The following is a description of a gene set: Human Gene Set: GOCC_CILIARY_BASAL_BODY A membrane-tethered, short cylindrical array of microtubules and associated proteins found at the base of a eukaryotic cilium (also called flagellum) that is similar in structure to a centriole and derives from it. The cilium basal body is the site of assembly and remodeling of the cilium and serves as a nucleation site for axoneme growth. As well as anchoring the cilium, it is thought to provide a selective gateway regulating the entry of ciliary proteins and vesicles by intraflagellar transport. studied in species Homo sapiens, and this is the list of marker genes: CBY1, CROCC (ciliary rootlet coiled-coil, rootletin), MARK4, TOGARAM1, PDZD7, SSX2IP, TAPT1, SPATA7, CAMSAP3, TACC3, PTK2, CEP20, OCRL, UTRN, CKAP5, ADH1A, FAM184A, USH2A, SCLT1, SSNA1, DLG5, TTLL7, CETN3, PRKCZ, CFAP184, MAP4, TTLL11, CEP250, AHI1, RILPL1, ALMS1, TBC1D31, ADCY9, NEK2 (NCBI Gene Id 4751), IFT88, ARMC9, MLF1, DCTN1, CIP2A, MKKS, KMT5B, RAB6D, PRKAA1, ENKD1, CSPP1, CFAP206, CFAP298 (cilia and flagella associated protein 298), ALPK1, SMAD4, TBC1D7, MAPK1, CEP290, AXDND1, TUBGCP5, RUVBL2, CAMSAP2, EGFR, CHRM2, CILK1, WDR90, RTTN, GUCA1B, SMG6, RAB6B, FBF1, STIL, PQBP1, CCSAP, RILP, CSNK1A1, IFT81 (intraflagellar transport 81), RAB6C, CCDC146, ACAA2, IFT172, FBXW8, NIN, SMAD3, CPLANE2, CREB1 (NCBI Gene Id 1385), CCDC178, RAB11FIP5, TTLL9, CIMAP3, AKT3, KIF11, LRRK2, PCM1, MAPRE1, INTU, CC2D1A, DZIP1, NAA11, PJA2, CDC45, BRAF, MICAL1, EZR, PSME3, NFE2L2, ARHGAP35, BBOF1, MAP2K1, LCA5, SKA1, PRKD3, KNCN, ADH1B, KLHL4, CFAP20, TTLL5, JADE1, CFAP126, TBATA, SPAG5, AKT1, CETN2, PRKAA2, ADH1C, DNAAF2, CIBAR1, TULP3, HRAS, CFAP100, DAAM1, CHRNA3, BBS2, GLI1, CEP350, DYNC2I2, PSMB4, CDK10, CDKN1B, CEP19, ZNF330, NCBP2 (nuclear cap binding protein subunit 2), BBS7, BCL3, ERC1, KATNIP, CKAP2, SAXO2, CEP89 (centrosomal protein 89, NCBI Gene Id 84902), CFAP410, ABCC3, CEP78, PKHD1, CDK5RAP2, HAUS7, DIS3L, SDCCAG8, WDR35, ACLY, AGTPBP1, RUVBL1, NME3, RPAP3, TCHP, IFT57, TTC8, IFT140, CENPF, TCEA2, C11orf97, IQCD, NEDD9, TUBG1, IFT80, OFD1, NEDD1, TTLL1, FANK1, IFT46, KIAA0753, PIN1, CEP68, DAW1, MAPK15, GNAI3, IFT20, CEP63, MME, PDIA6, HDAC6, LUZP1 (leucine zipper protein 1), POC1B, GLE1, MKS1, RAB6A, CCDC50, IFT122, CNTROB, SEMA4D, PRKCA, RILPL2, FAM161A, CFAP70, GAS2L2, KIF7, SPICE1, GLI2, CNTRL (NCBI Gene Id 11064), PPP4R4, EFHC2, IPMK, RPGRIP1L, RAB11FIP3, MYOF, ADRB2, TTLL13, ODF2L, ARL3, GAS8 (NCBI Gene Id 2622, growth arrest specific 8), POGZ, BUB1B, PIBF1, DYNC2LI1 (NCBI Gene Id 51626), POC1A, MAK, CFAP157, RAB8A, CFAP263, CCDC170, GNAI1, KIF20B, ATP2B4, CCDC66, MAPKAPK2, CTNND1, CIMIP2A, RABL6 (RAB, member RAS oncogene family like 6), ABRAXAS2, SAXO4, GABARAPL1, CCDC88A, RAB3IP (NCBI Gene Id 64325), CCDC61, TTBK2, MARCHF7, NUP85, POLA2, AURKA (NCBI Gene Id 8465), CEP44, CCDC81, SMAD6, CEP170, FZD6, CEP131, ARL2BP (NCBI Gene Id 23568), RRM1, DISC1, CEP41, CEP162, HIPK1 (NCBI Gene Id 23323), TRAF3IP1, USH1G, S100B, SNTB2, MAPK3, CENPJ, LRRC45, CTNNB1, SPACA9, PSMC4, NPHP4, TOPORS, BBS9, NME7, GNAI2, KIF2A, CYLD, EVC, IFT52, CDC14A, CEP72, ODF2, RAB28, TTLL6, CSNK1D, ATF3, RABL2B, TTLL4, RAB23, DZIP1L, AGBL2, WDR11, STING1, BBS5, CCDC14, RP2, TBC1D30, SAXO1, KIFAP3, ATXN10, CDKL5, B9D2, TTLL2, CFAP90, CIBAR2, ARL13B, ARL2, TUBGCP2, AGBL4, B9D1, PRPF6, MNS1, CCDC65, SMAD7, CEP152, NEK4, KIAA0586, TP73, KIF17, WRAP73, RABEP2, PTPN23, PKD2, DYNC2I1, ODAD3, VCP, PIK3R4, EPB41L3, WHRN, ENTR1, BBS4, FFAR4, RPGR, HAUS3, NCAPD2, BAG3, SLC1A5, TSC1, TEK, IFT43, IFT56 (intraflagellar transport 56), CADPS2, C2CD3